The following is a description of a gene set: Mouse Gene Set: GOBP_REGULATION_OF_THYMOCYTE_APOPTOTIC_PROCESS Any process that modulates the occurrence or rate of thymocyte death by apoptotic process. species: Mus musculus, and this is the list of marker genes: Rag1, Efna1 (ephrin A1), Bbc3, Adam8, Nfkbid, Ada, Kifap3, Bcl11b, Casp8, Wnt5a (NCBI Gene Id 77565), Jak3, Ptcra, Rorc, Hif1a, Bmp4, Blm, Vhl, Trp53, Zc3h8